Given this list of marker genes Spef1, Septin10 (septin 10), Ssxb15, Akap4, Cimip2b, Met, Gstm5, Efhb, Rsph4a, Spata19, Dynlt4, Ropn1l, Prkaca, Spaca3, Rabl2, Cfap58, Gabarap, Pierce1, Ropn1, Mns1, Calm1, Rsph3a (NCBI Gene Id 98093), Slc26a3, Kif2a, Ccdc38, Tuba1a, Tcte1, Rsph1, Usp26, Tekt5, Txndc8, Catsperg1, Cetn2, Ak1 (NCBI Gene Id 59018), Ppp3r2, Zmynd12, Atp1b3, Slc26a6, Tssk4, Spata3, Ssxb5, Spag6l, Tekt2, Tacr1, Dnai1, Aldoa, Cfap95, Iqub, Saxo2, Qrich2, Ssxb8, Dnah7c, Tppp2, Cfap210, Spag16, Ift88, Cfap70, Cfap65, Cfap141, Catsper2, Ace, Cfap221, Atp1a1, Dnah12, Ift27, Ldha, Hsp90aa1 (NCBI Gene Id 15524), Dnah6, Pmfbp1, Hspd1, Ppp3cc, Abhd2, Pgk2, C2cd6, Catsper4, Tekt4, Ssxb6, Odf2, Flacc1, Dusp21, Dync2h1, Rsph9, Kcnu1, Drc3, Ttll3, Nherf1 (NCBI Gene Id 26941), Oaz3, Cst11, Aldoart1, Ran, Lyzl4, Irgc, Dnah17, Tmem232 (transmembrane protein 232), Defb37, Cfap119, Ttll8, Ccdc181, Ccdc172, Cfap53, Fsip2, Cfap45, Catsperz, Pacrg (NCBI Gene Id 69310), Vps13a, Septin6 (NCBI Gene Id 80615), Catsperg2, Dnah9, Slc9b1 (solute carrier family 9, subfamily B (NHA1, cation proton antiporter 1), member 1), Dnah14, Hyal3, Bbof1, Omp, Tcp11x2, Tubb4b, Cabcoco1, Cfap251, Tmem249, Gas8, Cul3, Pierce2, Spmip10, Tcp11, Odf4, Cfap20, Dnah2, Ptchd3, Efcab9, Dnah1, Pde1a, Spag8, Ttc29 (tetratricopeptide repeat domain 29), Tssk6, Ift81, Cimip2c, Dynlt2a1, Cd52, Spmip9, Tomm20, Vdac2, Spag6, Cabyr, Atg16l1, Atp2b4, Akap9, Rsph3b, Slc26a8, Spa17, Dcdc2c (doublecortin domain containing 2C), Akap14, Cabs1, Lrrc46, Cfap144 (NCBI Gene Id 75429), Septin4, Tsga10, Scnn1a, Cfap43, Catsperb, Ift172, Odf1, Garin2, Cimip2a, Dnajb13, Enkur, Dnah11, Ccdc42, Fscb, Defb1, Tacr3, Txndc2, Efhc1 (EF-hand domain (C-terminal) containing 1), Gk2, Clxn, Ccr6, Spaca9 (sperm acrosome associated 9), Pfkm, Odad4, Tssk3, Ribc2, Cfap52, Ssxb16, Mroh2b, Tacr2, Rnf38, Efcab2, Cimap1a, Hvcn1, Catsperd, Spata33, Wbp2nl, Gapdhs, Drc1, Saxo1, Septin12, Ssxb13, Rho, Septin7, Cfap107, Drd2, Cfap68, Lyzl6, Ribc1, Atp1a4, Tektl1, Cfap74 (cilia and flagella associated protein 74), Grk3, Cfap90, Spmip6, Atp1b1, Spmip5, Ssxb14, Tekt3 (NCBI Gene Id 71062), Adgb, Ak2, Tekt1, Cfap276, Ak8, Spef2, Fhad1, Nme7, Efhc2, Ssxb10, Cfap126, Saxo4, Lrrc23, Cfap57, Morn5, Dnah7b, Slc9b2, Pcdh11x, Odad3, Tbc1d21, Dusp3, Cep164, Ccdc39, Dydc1, Rsph6a, Ssxa1, Dnah10, Il4i1, Eno4, Cfap61 (cilia and flagella associated protein 61), Crocc, Cfap161, Dnah3, Spaca5, Catspere2, Catsper1, Spata18, Dnhd1, Ssxb3, Rpgr, Hydin, Catspere1, Sqstm1 (NCBI Gene Id 18412), Kif9, Ccdc34, Dnah5, Marcks, Cimip4, Nek5, Ssxb1, Spmip8, Nme8, Slirp, Akap3, Ct55 (NCBI Gene Id 75013), Pgam1, Ddx6, Slc22a14, Dnai2, Efcab6, Iqcg, Dnah7a, Rap1a, Rsph14, Nme5, Ctsh, Tektip1 (NCBI Gene Id 432479), Dnah8, Septin2, Dnali1, Cfap69, here is a description of the gene set: Mouse Gene Set: GOCC_9PLUS2_MOTILE_CILIUM studied in species Mus musculus A motile cilium where the axoneme has a ring of nine outer microtubule doublets plus two central microtubules (and is therefore called a 9+2 axoneme).